The following is a description of a gene set: Human Gene Set: GSE9960_GRAM_NEG_VS_GRAM_NEG_AND_POS_SEPSIS_PBMC_UP To identify signature genes that help distinguish (1) sepsis from non-infectious causes of systemic inflammatory response syndrome, (2) between Gram-positive and Gram-negative sepsis. species: Homo sapiens Genes up-regulated in peripheral blood monocytes (PMBC): Gram negative sepsis versus mixed infection sepsis. from publication Payen D, Lukaszewicz AC (PMID 19535937), and this is the list of marker genes: TBX5-AS1, BTBD19, CLCN6, IFIT3, VRTN, LY75, TMEM41A, EBI3, JAK3, IFIT2, TXN, CCL5, NBAT1, VRK3, GRIN2D, CDH18, LCN1, LARP7, PRSS2, DLX2, MMP24 (NCBI Gene Id 10893), DGKA, KCNE1, LINC00491, MUC6, REC8, NCR2, HELZ2, TMEM252, ENSG00000237870, AK4, WWC1, USP18, PASK, MDGA1, OAS2, BASP1, MC1R, TNPO2, ZNF827, IFITM2, SHISAL1, LAD1, UPK2, FSCN1, SPTBN2, PCGF5, CUL1, DLG3, SIX1, ECE1, NSMF, GNG4, ELAVL3, NFATC2IP, GTPBP4, FENDRR, AXIN2, OTUD5, PAX6 (paired box 6), MTRF1L, CXCR6, SHFL, CHST2, CADM4, ETV3 (NCBI Gene Id 2117), CDHR2, CYP19A1, SCN5A, SP140, ADCY1, PNRC2, SLAMF7, PDZD9, IFI44, CHTOP, TCF7, IFI44L (NCBI Gene Id 10964), STAT1, ATOSB, BDKRB1, RAB40A (RAB40A, member RAS oncogene family), CC2D1A, SAMD9L, SP110, LINC02210, ASIC4, TAB1, PNPT1, RBBP8NL, IFITM1, GRIK4, GPRIN2, MBD2, LINC02800, OR1J4, PARP14, IGKV4-1, MPHOSPH10, GLP1R, TMEM30B, MIR23AHG, POU3F4, MATCAP1, LRRC17, MYH10, SYT5, PPARGC1A, BTG1, DTX2, DLGAP4, GAL3ST1, HTR3B, PTPRF, SLCO5A1 (NCBI Gene Id 81796), EPM2AIP1, CFB, NEUROG1, ADAMDEC1, CSPG4BP, TUBB4B, HBM, SHROOM3, GSX2, RRAGC, PCSK9, ZGPAT, CARINH, CARMIL2, MIR3142HG, NEURL3, TM6SF2, NPBWR1, MIP, IFITM3, LENG9, ALOX15B, H2BC8, MAN1B1-DT, STAT2, TRDN, KLF5, TNFAIP6 (NCBI Gene Id 7130), ESPNL, XAF1, KLHL1, MMP28 (matrix metallopeptidase 28), CDKN2A, PDE6G, BRCA1, H2BC21, RUFY3, SCP2D1-AS1 (SCP2D1 antisense RNA 1), CERS3, HRG, LINC00511, HES4, COBL, KRTAP7-1, DDX50, IQCC, TRAF1, NAPA, CES4A, HCN3, SCART1, EFNA5, WHAMM, LINC01118, NDP, TNFRSF9, CRLF2, IFIT1, NUB1, IDO1, HAGH (hydroxyacylglutathione hydrolase), TSPAN33, PTCD1, ISG20, ANKRD33B, UNC93B1, FLJ30679, NLRC5, CALCA, NYX, MX1, SLC18A3, FGF17, IL4R, LSS, IGF2-AS